The following is a description of a gene set: studied in species Mus musculus Mouse Gene Set: GOBP_COLLATERAL_SPROUTING The process in which outgrowths develop from the shafts of existing axons., and this is the list of marker genes: Ptprs, Fstl4, Rgma, Rnd2, Wnt3, Ist1, Dcx, Sema4d, Wnt3a, Spart, Dvl1, Prkg1, Npr2, Efna5 (ephrin A5), Cd2ap, Zeb2, Ngf, Lrp1, Bcl11a, Nfix, Septin7 (septin 7, NCBI Gene Id 235072), Bdnf, Ulk2, Fgf13, Epha7, Hdac6, Lpar3, Crabp2 (NCBI Gene Id 99759), Ifrd1, Ulk1, App, Spg21 (SPG21, maspardin), Nin, Cobl, Omg